The following is a description of a gene set: species: Homo sapiens from publication Aizarani N, Saviano A, Sagar, Mailly L, Durand S, Herman JS, Pessaux P, Baumert TF, Grün D (PMID 31292543) Human Gene Set: AIZARANI_LIVER_C25_KUPFFER_CELLS_4, and this is the list of marker genes: PHACTR1, PABPC1, IRF4, CMTM6, TNFSF13B, CLEC7A, TGFBI, BASP1, SGK1, HLA-DQB1, ITGAX, ADGRE2, GPX1, FCN1, GZMB, GRN, IL1B, PPT1, SLC15A3, CCDC88A, HLA-DRB1, CPVL, C1orf162, KDM6B (lysine demethylase 6B), EREG, LIMS1, LRRFIP1, RGS1, CD83, CD1C, KLHL6, HLA-DMB, PLAUR, RNF144B, ATP1B3 (ATPase Na+/K+ transporting subunit beta 3), STK17B, PMAIP1, KCTD12, RGCC, TET2, SELL, FCGR2A, HLA-DPB1, HLA-DRB5, IGSF6, LAPTM5, REL, GAPT, LYN, CD86 (CD86 molecule), PSAP, AP1S2, JARID2, CTSS, HLA-DRA, IL1R2 (NCBI Gene Id 7850), ITGB2, CD163, B3GNT5, PTPRE, CXCL8, GPAT3, ZEB2, SERPINB9, MIS18BP1, OGFRL1, MACROH2A1, CYBB, GNA13, RHOQ, EMILIN2, MS4A7, POU2F2, CSF1R, FGL2, THBD (thrombomodulin), DDX21, IL1RN (interleukin 1 receptor antagonist), NCF2, HERPUD1, CD55, HLA-DPA1, HLA-DMA, RILPL2, LILRB1, SAMSN1, SAMHD1, ICOSLG, PSTPIP2, AIF1, HBEGF, LGALS9, HLA-DQA1, CLEC10A, IRAK3, AREG, FCER1G, CXCL3, IL13RA1, MARCHF1, FGD4, LYZ, RGS2, IRF8 (NCBI Gene Id 3394, interferon regulatory factor 8), NLRP3, FLT3, VIM, MAFB, FGR, LILRB2, THBS1, ZNF331, MAP3K8, PTK2B, TMSB10, THEMIS2, RPL36A, S100A11, KLF4, HLA-DOA, SAT1, AHR, FPR1, VEGFA, LST1, CST3, ARRB2, RNASE6, HCLS1, VCAN, MNDA, METRNL, C5AR1, TLR2, LILRB3, IER3, ADA2, SH2B3, CIITA, NPC2, CLN8, NR4A2, SRGN, CXCL16, PLD4, MPEG1, JAML, PABPC4, HCK, FTH1, FCER1A, ACTB, COTL1, RNASET2 (ribonuclease T2), LITAF (lipopolysaccharide induced TNF factor), TNFRSF1B, TYROBP, CLEC4E, HSPA6, RAB31, SYK, H3-3A, GPR183, ATP6V1B2, CELF2, SLC11A1, PLEK, EVI2B, CXCR4, ATP2B1, NR4A3, ANXA1, NAMPT, CNTRL